Given this list of marker genes VAMP1, NCBP3, MAP2, ARK2N, SCUBE3, SLC9A9, NRAS, TCF4, ASIC2, RNF11, GRIN2B, ARPC2, PDHA2, SENP1, MAP4K5, ZNF516-DT, CREB5, KLF14, CITED2, USP2, PCF11, ALX1, IL17B, here is a description of the gene set: Genes having at least one occurrence of the motif ACAAGATAA in the regions spanning 4 kb centered on their transcription starting sites. This matches the EVI1 transcription factor binding site V$EVI1_06 (v7.4 TRANSFAC). species: Homo sapiens Human Gene Set: EVI1_06